The following is a description of a gene set: TFs and nuclear. species: Homo sapiens Human Gene Set: MODULE_252, and this is the list of marker genes: SNRPB2, ADNP2, JUNB, ILF3, TENT4A, TAF11, MAPK14, TSN, SSB, NCAPD2 (non-SMC condensin I complex subunit D2), CENPA, SOX4, E2F3, TOP2A, PPP4C, CCNA2, HLTF, TAF6, CCNE2, SRSF10, HNRNPF, CDC7, GNL2, CTCF, SNRPE, CDC5L, KIF23, GTF2I, XRCC5, LRP8, POLD1, MNDA, DEK, HNRNPR, ZFP36L1, MYO18A, MSH2, WEE1, HMGN4, LMO2, CCNB2, CBX4, MEIS1, MLH1, CSNK2A1, NUP153, ILF2, KHSRP, CDKN1A, CHAF1B, XRCC3, STMN1, NCBP2, SRSF2, SFPQ, NFYA, MYC, TAF7, POU4F1, CCND2, POLD2, POLR2D, SRPK2, POLR2F (RNA polymerase II, I and III subunit F), MSX1, SUMO1, NASP, KMT2D, TRIP13, CSRP2 (cysteine and glycine rich protein 2), CDKN2A, DNMT1, CDC25C (NCBI Gene Id 995), RPA1, SMC2, TRA2B (NCBI Gene Id 6434), SNRPD1 (NCBI Gene Id 6632), SLBP, PLK1, HMGB2, RAD21, MAD2L1, IPO7, TAF4, MLF1, CDK7, ZNF43, CCNT1, COIL, H2AX, BARD1, APEX1, RAD51, ZWINT, UNG, MYCN, CDC45, PER1, STK38, RFC4, POP7, PCNA, PNN, PSMD12, NDC80, HMGB1, APLP2, PHLDA1, RPA3, CSE1L, PRP4K, SRSF7, DR1, SNW1, KRT17, GTF2F2, PSMA2, MCM6, MAP2, EZH2, TLX2, FEN1 (NCBI Gene Id 5882), SLU7, MAZ, KMT2A, ASAP2, CMPK1, PAX6, STAMBP, SOX9, TMPO, AKT1, CBX1, COPS2, MAFG, MCM3, POLE2, CENPF, STAT1, DCK, CALU, DHX9, POLA1, H2BC21, KNTC1, CCNO, HSF2, TOPBP1, RBBP4, KIF2C, FOXM1, DDX5, H2AZ1, NME1, YBX1, CBX5, PRPF8, HOXA13, JUN, ZNF146, CDKN2C, SSRP1, ZNF217, ACTL6A, TNPO1, RFC3, NFATC4, BIRC5 (baculoviral IAP repeat containing 5), ORC1, SAP30, SRSF1, HDAC1, HNRNPA3P1, MPHOSPH6, ZNF124, MYBL2, DGKI, PSMD2, DLX5, CDK1, RAD54L, RCC1, PPP2R5D, DYRK1A, CCNB1, PRIM1, KHDRBS1, H2BC12, NEK2, PSMC4, LSM1, PSMD10, SNRPC, FOSL1, DDX23, RFC5, CENPE, NEK4, HNRNPA0, E2F1, CDK4, RAD51C, UBE2A, RAD51D, PTTG1, WDHD1 (NCBI Gene Id 11169), ZBTB25, LIG1, HAT1, RPA2, FOS, TFDP1, LMNB1, PSMA4, BMI1, VPS72 (NCBI Gene Id 6944), BUB1 (BUB1 mitotic checkpoint serine/threonine kinase), PRKDC, SNRPA1, NUP107, NME2, KATNB1, NELFE, RAD23A, RECQL4, EWSR1, PRIM2, PSMB5, NAP1L1, RNMT, CHAF1A, HDAC2, HR, RAN, DSP, FOXG1, LHX2